The following is a description of a gene set: studied in species Mus musculus Mouse Gene Set: GOBP_POSITIVE_REGULATION_OF_TROPHOBLAST_CELL_MIGRATION Any process that activates or increases the frequency, rate or extent of trophoblast cell migration., and this is the list of marker genes: Apela, Smurf2, Ago2, C1qbp, Acvr1b, Vegfa, Syde1